Given this list of marker genes MRFAP1L1, MFSD14A, NFYB, INPP5F, CD300LF, SEC16B, TCEAL8, NAPSA, C4orf51, ERMP1, CRISPLD1 (cysteine rich secretory protein LCCL domain containing 1), PATL2, PPM1L, PCDH11X, ACP7, NLRP3, PRKAA2, IKZF2, TFAM, NCBP3, ACOT11, TLE2, EMILIN2, FAR2 (NCBI Gene Id 55711), HNRNPLL, FAM163A, LZTS3, DAB2IP, NRN1, PRRG2, BHLHA9, TMEM107, TBC1D30, WDR81, TMEM119 (NCBI Gene Id 338773), INPP5A (NCBI Gene Id 3632), KIAA1958, TDRD5, DMRTC1B, ETFBKMT, DAW1, ZFYVE9, GPR15, IL18 (NCBI Gene Id 3606), MDH1, C3orf70 (NCBI Gene Id 285382), CBR4, LRRC57, KHDC1L, ZNF862, N4BP1, GPT2, PRICKLE1, MANBA, IL1RL1, GPR160, BAALC, EGR3, RFESD, MATN2 (matrilin 2), AK7, FRMD5, SV2C, MAN1A1, GNAT1, GNG12, RETREG1, SOCS5, KRTAP21-1, SMAD3, AKR1C2, TMEM59L, NDFIP1, SH3GL3, ITGAV, CILP2, ITIH5, FGF16, MYO3B, PFKFB2, ZCCHC18 (NCBI Gene Id 647692), ANXA8, AS3MT (arsenite methyltransferase), ELOVL6, DCAF5, DMD, YAP1, GTDC1, NMU, IGF2BP3, VAV2, SLC9B2, SLC16A9 (solute carrier family 16 member 9), SHMT1, SLC17A5, RAP2A, FXYD2, RAB10, ADPRHL1, IKZF4, JAKMIP2, BCLAF3, OR51E2, ARMCX4, TTN, SRXN1, RIN2, HTRA4, CEP112, P2RX4, RHOBTB1, ARHGDIG, PRSS41, PYGM, MB, IL1RN, MRPS6 (NCBI Gene Id 64968), OXTR, HAPLN1, GATA3 (GATA binding protein 3), SULT1A1, DYRK3, SPTLC1, ENPP4, NTMT2, ACOT9, GRIN2A, PLAGL1, GIPR, UBE2V1, PEX11A, IZUMO1R, LCLAT1, PDE10A, LMAN1, FAM217B, LOXL3, SRD5A2, EPHB2, SUSD4, SUFU, RAPH1, SREK1, NEIL1, ZBTB34, AUTS2, IL17RB, TRIM31, ANK3, LAG3, ALK, XXYLT1, ATG5, PRNP, PIK3R3, ARL8B, NCKAP5, ZBED5, LIG1, ARG2, TRAM1L1, ZSCAN12, ZDHHC15, SLC35F5, PARD6G, CCRL2, NUCB2, TMEM42, TTR, EGLN3, CFAP53, NRP1, COPZ2, SOCS2, AMOTL2, PIWIL2, LRRN4, CABS1, GNB4, PGGHG, ODF4, SCAMP1, SH2D1A, CD200R1, GLIPR1, PMEL, SOHLH1, SCEL, GPIHBP1, DHRS3, LRBA, BCAP29 (NCBI Gene Id 55973), GSR, CASP3, GNPNAT1, ENO2, ADAMTS6, PPME1, NKX2-2, TMEM169, here is a description of the gene set: Human Gene Set: GSE20366_TREG_VS_TCONV_UP Genes up-regulated in comparison of TregCD103-Klrg1 versus TconvLP (see Table 1S in the paper for details). studied in species Homo sapiens Regulatory T (Treg) cells that express the FoxP3 transcription factor are essential for lymphoid homeostasis and immune tolerance to self. Other non-immunological functions of Treg cells, such as controlling metabolic function in adipose tissue, are also emerging. Treg cells originate primarily in the thymus, but can also be elicited from conventional T cells by in vivo exposure to low-dose antigen or homeostatic expansion, or by activation in the presence of TGFβ in vitro. Treg cells are characterized by a distinct transcriptional signature controlled in part, but not solely, by FoxP3. For a better perspective on transcriptional control in Treg cells, we compared gene expression profiles of a broad panel of Treg cells from various origins or anatomical locations. Treg cells generated by different means form different sub-phenotypes identifiable by particular combinations of transcripts, none of which fully encompass the entire Treg signature. Molecules involved in Treg effector function, chemokine receptors, and the transcription factors that control them are differentially represented in these subphenotypes. Treg cells from the gut proved dissimilar to cells elicited by exposure to TGFβ, but instead they resembled a CD103+Klrg1+ subphenotype preferentially generated in response to lymphopenia. from publication Feuerer M, Hill JA, Kretschmer K, von Boehmer H, Mathis D, Benoist C (PMID 20231436)